Given this list of marker genes Hrh3, P2rx7, Htr2c, Sv2a, Slc6a1, Trh, Htr1b, Grik1, Htr1a, Gabbr1, Ntsr1, Htr6, Abat, here is a description of the gene set: Mouse Gene Set: GOBP_REGULATION_OF_GAMMA_AMINOBUTYRIC_ACID_SECRETION species: Mus musculus Any process that modulates the frequency, rate or extent of the regulated release of gamma-aminobutyric acid.